Given this list of marker genes Zfpm1, Gata3, Prkcq, Zp3, Fcer1g, Tnfsf4, Lef1, Cd83, Cd28 (NCBI Gene Id 12487), Notch1, Cd1d1, Ddit3 (DNA-damage inducible transcript 3), Txk, Cebpb, Cd40lg, Irf4, Scgb1a1, Prkcz, Cd1d2, Havcr2, Vtcn1, Itk, Fosl2, Rara, Rbpj, Prg2, Epx, Il20rb, Mir301, Icosl, Nlrp3, Il1rap, Foxp3, Syk, Sash3, Slc7a5, Il33 (NCBI Gene Id 77125), Zg16, Cd3e, Notch2, Ndfip1, H2-T23, here is a description of the gene set: The appearance of interleukin-4 due to biosynthesis or secretion following a cellular stimulus, resulting in an increase in its intracellular or extracellular levels. Mouse Gene Set: GOBP_INTERLEUKIN_4_PRODUCTION species: Mus musculus